Given this list of marker genes Abcd3, Star, Cyp8b1 (NCBI Gene Id 13124), Sirt1, Pex2, Cyp7b1, Amacr, Baat, Lep, Hnf1a, Fabp6, Abcb11, Malrd1 (NCBI Gene Id 64662), Slco1a6 (solute carrier organic anion transporter family, member 1a6), Ces1h (carboxylesterase 1H), Acaa1a, Errfi1, Prox1, Arv1, Ces1e, Scp2, Acox2, Cyp7a1, Ces1d, Cyp39a1, Ces1a, Sult2a8 (sulfotransferase family 2A, dehydroepiandrosterone (DHEA)-preferring, member 8), Slc27a5, Hsd17b10, Fgf15, Gba2, Cyp27a1, Ces1g, Atp8b1, Acaa1b (NCBI Gene Id 235674), Ugt2a2, Ces1b, Stard4, Nr1d1, Ces1c, Fgfr4, Ugt2a1, Ces1f, Slc27a2, Nr5a2, Npc1, Pank2, Kit, Akr1d1, Nr1h4, here is a description of the gene set: species: Mus musculus Mouse Gene Set: GOBP_BILE_ACID_METABOLIC_PROCESS The chemical reactions and pathways involving bile acids, a group of steroid carboxylic acids occurring in bile, where they are present as the sodium salts of their amides with glycine or taurine.